Given this list of marker genes SOCS7, NUP50, STK4, MED13L, SELPLG, TRIM27, ANAPC13, SDC2, MNDA, LCLAT1, MPZL1, CREB5, UGGT1, WAS, CHST14, MIR646HG, GIMAP8, RAB11FIP1, KIAA0040, ORAI2, MLXIP, HERC1, HMOX2, TMX4, UCP2, WASF2, TACC1, RABGAP1L, TAX1BP3, KIT, SLC25A28, NUDT16L1, RFLNB, PXN, RTL10, TIGD3, CLPTM1 (CLPTM1 regulator of GABA type A receptor forward trafficking), ZMAT3 (zinc finger matrin-type 3), CCDC69, TP53INP1, DGCR2, YPEL2, MAT2B, ZC3H13, MPPE1, NFATC3, MAP3K5, BRI3BP, ZNF217, LPGAT1, SLC66A3, PRIMPOL, H2AZ1, PSMB6, GALNT10, FAR1, CBX3P2, MSRB2, PPP1CA, MBTD1, RNF114, RPGRIP1, HNRNPUL1, TOPORS, CDK6, MARCHF7 (NCBI Gene Id 64844), HDAC1, ZNRF2, LIMD2 (LIM domain containing 2), MARCHF8, HAUS4, STRAP, TGFBR2, MIR21, MICALL1, ICAM3, CASP8, IQGAP2, TNFSF13B, FRAT2, RGS18, WDR1, ACP3, CTSS, ZFP36L2, TESMIN, SLC8B1, IRF2BPL, VCL, EPB41 (erythrocyte membrane protein band 4.1), TRIM41, LRRC57, BICD2, ACTL6A, CA4, ZBTB44, GIMAP4, KCTD12, MANSC1, FAM8A1, UBE3C, BRAT1, ST6GAL1, NUB1, SNX18, PAXIP1-DT, TBCC, CRLF3, IGF2R, CUL3, CASP3, NTAN1, DEF8, TBC1D13, PCNA, LY75, MSRB1, EIF3K, PKN2, ZMPSTE24, PPP6C, BTBD6, HVCN1, IMPACT, UPF2, ADD3, ABCC5, VPS36, DPY30, VPS4B, NCBP2AS2, NCOA4, TBC1D14, TMT1A, AGO4 (argonaute RISC component 4), HSD17B12, SMAP2, NLK, STMN3, G6PD, DDX28, STXBP5, STK17B, PPM1F, SLC40A1, ABHD13, PEX12, LRRK1, CXCL6, FAM174A, ADD1, DPEP2, CHMP1B, TUBA1A, HECTD3, PDE3B, SLC30A1, MMGT1 (membrane magnesium transporter 1), MTURN, VCP, CD46, HSPA8 (heat shock protein family A (Hsp70) member 8), NHS, CCM2, OGFRL1, TLR1, HENMT1, ARHGEF6, TBL1X, CAMSAP1, TMCC1, CCNY, UBE4B, ATG2B, RETREG3, RAB3D, SPIDR, GMCL1, ERP27, FAM117B, CCN3, GABPB1-AS1, ARHGAP1, XRN2, PSMA3, P2RY10, HHEX, RIC8A, MYO5A, RMI1, ADI1, ADAM19, CERS2, MAP3K14 (NCBI Gene Id 9020), LRP10, here is a description of the gene set: Human Gene Set: GSE37416_CTRL_VS_12H_F_TULARENSIS_LVS_NEUTROPHIL_UP We demonstrated recently that both constitutive and FAS-triggered apoptosis of human neutrophils are profoundly impaired by Francisella tularensis, but how this is achieved is largely unknown. To test the hypothesis that changes in neutrophil gene expression contribute to this phenotype, we used human oligonucleotide microarrays to identify differentially regulated genes in cells infected with F. tularensis strain LVS compared with uninfected controls. In order to examine the effect of F. tularensis on the neutrophil transcriptome, we performed microarray expression analysis on human neutrophils treated with F. tularensis subsp. holarctica live vaccine strain (LVS). from publication Schwartz JT, Bandyopadhyay S, Kobayashi SD, McCracken J, Whitney AR, Deleo FR, Allen LA (PMID 22986450) Genes up-regulated in comparison of control polymorphonuclear leukocytes (PMN) at 12 h versus PMN treated with F. tularensis vaccine at 12 h. studied in species Homo sapiens